The following is a description of a gene set: from publication Tabula Muris Consortium (PMID 32669714) Mouse Gene Set: TABULA_MURIS_SENIS_HEART_AND_AORTA_ENDOCARDIAL_CELL_AGEING studied in species Mus musculus, and this is the list of marker genes: Rpl37, Lgmn, Rbm3, Cd74, Rps18, Rpl37a, Rps3, Rpl39, H2-K1, Rps15a, Rps12, H2-D1, B2m, Rps23, Rps21, Rplp2, Rps20, Rpl31-ps12, H2-Q4, Rps29, Rpl12, Rpl36, Nppa, H2-Ab1, Rpl32, Lrg1, Rps10, Rps24, Rpl23, Rpl6, Rpl38, Rpl31, Ccn1, H2-Aa, H2-Eb1, Rps28, Junb, Serping1, Rplp0, Eef1a1